Given this list of marker genes Tcf25, Trim44, Gabarap, Birc2, Nmi, Ppia (NCBI Gene Id 268373), here is a description of the gene set: Any process that modulates the rate, frequency or extent of protein K-48-linked ubiquitination, a protein ubiquitination process in which a polymer of ubiquitin, formed by linkages between lysine residues at position 48 of the ubiquitin monomers, is added to a protein. K48-linked ubiquitination targets the substrate protein for degradation. studied in species Mus musculus Mouse Gene Set: GOBP_REGULATION_OF_PROTEIN_K48_LINKED_UBIQUITINATION